Given this list of marker genes UBE2B, SHOC1, C14orf39, P3H4, TRIP13, SPO11, REC8, TEX11, TERB2, BAG6, SYCP1, STAG3, MCMDC2 (NCBI Gene Id 157777), PLK1, HORMAD1, MLH3, MEIOC, SYCE1L, EHMT2, AGO4, C1orf146 (chromosome 1 open reading frame 146), SYCE3, SYCP2, TEX15, HSPA2, SYCE2, TEX12, SYCE1, here is a description of the gene set: A process that is carried out at the cellular level which results in the assembly, arrangement of constituent parts, or disassembly of a synaptonemal complex. A synaptonemal complex is a proteinaceous scaffold formed between homologous chromosomes during meiosis. studied in species Homo sapiens Human Gene Set: GOBP_SYNAPTONEMAL_COMPLEX_ORGANIZATION